The following is a description of a gene set: Genes predicted to be targets of miRBase v22 microRNA mmu_miR_3090_3p in miRDB v6.0 with MirTarget v4 prediction scores > 80 (high confidence targets). from publication Chen Y, Wang X (PMID 31504780) species: Mus musculus Mouse Gene Set: MIR_3090_3P, and this is the list of marker genes: Arid4a, Brms1, Sp6, Tbxa2r, Vangl2, Stk3, Cgn, Gclc, Spred3, Mfhas1 (malignant fibrous histiocytoma amplified sequence 1), Kcns1, Maff, Rnf122, Cblb, Slco5a1, Bean1, Sv2b, C1qtnf9, Entpd5, Nasp, Phf21a, Acp2, Dus4l, Agap1, 1700037C18Rik, Nthl1, Serpine2, Pdcd6, Gatad1, Usp32, Srf, Ubqln1, Mbd4, Ccdc184, C2cd2l, Rasal2, Ppp2r5d, Arhgef18 (Rho/Rac guanine nucleotide exchange factor 18), Cfap410, Ajm1, Upf2, Crtc1, Adcy9, Pak3 (p21 (RAC1) activated kinase 3), Gpatch2l (NCBI Gene Id 70373), B4galt1, Ppil2, Erfe, Onecut2, Polr1c, Thra, Nol12, Kcne1, Nsrp1, Ccdc85b, Mdga2, Capn5, Spring1, Micall1, Soat1, Kdm7a, Pan3, Adcy6, Czib, Mapk11, Tbc1d13, Abhd2, Grhl2, Bpifb4, Loxl3, Syne3, Ramp1, Prdm6, Zfp609, Pdap1, Ugdh, Accs, Vsir, Tmem71, Asic4, Nat8l, Slc35d1, Rnf43, Ube2i, Txndc9, Spry4